Given this list of marker genes Trim27, Ppp3cc, Ppp3r1, Ppp3r2, Ppp3ca, Wfdc6a, Hes1 (NCBI Gene Id 15205), Pawr, Eppin, Slc30a1, Spink1, Ppp3cb, Crhr2, Ace, Cav1, here is a description of the gene set: Any process that decreases the rate, frequency, or extent of the directed movement of calcium ions into a cell or organelle. Mouse Gene Set: GOBP_NEGATIVE_REGULATION_OF_CALCIUM_ION_IMPORT species: Mus musculus